The following is a description of a gene set: A 20S multiprotein assembly of total mass about 1.2 MDa that activates dynein-based activity in vivo. A large structural component of the complex is an actin-like 40 nm filament composed of actin-related protein, to which other components attach. Human Gene Set: GOCC_DYNACTIN_COMPLEX studied in species Homo sapiens, and this is the list of marker genes: ACTR1B, DCTN6, ACTR1A, DCTN2, DCTN3, DCTN5, DCTN4, ACTR10